The following is a description of a gene set: studied in species Homo sapiens Human Gene Set: HP_HYDRANENCEPHALY A defect of development of the brain characterized by replacement of greater portions of the cerebral hemispheres and the corpus striatum by cerebrospinal fluid (CSF) and glial tissue. Hydranencephaly, and this is the list of marker genes: ESAM, PHGDH, WDR81, NDE1, GPKOW, FLVCR2, CEP55, SNRPB, TBX15